Given this list of marker genes ALDH18A1 (aldehyde dehydrogenase 18 family member A1), MT-ND5, MT-ATP6, AASS, MT-TV, MT-TL1, MT-TK, PCK1, MT-ND4, ASL (NCBI Gene Id 435), MT-ND6 (NCBI Gene Id 4541), ATP5F1A, MT-ND1 (mitochondrially encoded NADH:ubiquinone oxidoreductase core subunit 1), SLC7A7, SLC25A15, CA5A, MT-TW, MRM2, CPS1, OTC, NAGS, ASS1, MT-ND2, MT-ND3, SLC25A13, here is a description of the gene set: Any deviation from the normal concentration of citrulline in the blood circulation. studied in species Homo sapiens Abnormal circulating citrulline concentration Human Gene Set: HP_ABNORMAL_CIRCULATING_CITRULLINE_CONCENTRATION